The following is a description of a gene set: studied in species Mus musculus Mouse Gene Set: GOBP_INTRACELLULAR_PHOSPHATE_ION_HOMEOSTASIS A homeostatic process involved in the maintenance of a steady state level of phosphate ions within a cell., and this is the list of marker genes: Xpr1, Umod, Slc34a2 (NCBI Gene Id 52185), Slc34a1, Abcc6, Slc34a3, Nherf1, Fgf23, Spp1, Gcm2, Enpp1